Given this list of marker genes PEX12, POMT1 (protein O-mannosyltransferase 1), PEX13, TRAF7, GLE1, CHRND, VCP, DLL4, KIF1B, TPM2, SNX10, ALG2, PEX3, HLA-DRB1, PEX14, SELENON, DNAJB6, PEX5, SUFU, SMARCB1, MYMX, SGCD, PI4KA, LRP12, DMPK, MYMK, ANTXR1, SLC39A14, TCIRG1, COL6A1, SOST, POMT2, MYPN, HK1, BIN1, LAMB2, CHKB, BAP1, ADNP, LRP4, SQSTM1, SLC25A4, SLC25A1, KLHL40, XRCC2, PEX1, PEX11B, MUSK (muscle associated receptor tyrosine kinase), FRG1, YME1L1, SYNE1, CHCHD10, SMO, CHD7, SUCLA2, MPZ, CNTNAP1, PEX10, DPAGT1, SRPX2, PIK3CA, SH3TC2, CHRNB1, SCN4A, ADCY6, MYO9A, ALG14, ITPR1, UBA2, NEB, ANKH, MYL2, FKRP, CRPPA, PTRH2, PEX6, TOR1A (torsin family 1 member A), NEFL, LARGE1, GSN, GJC2, BAG3, SIX5, TERT, SALL4, OSTM1, AKT1, MTM1, MTMR14, SEMA3E, TTN, ADA2, TWNK, TFAP2A, SIX1, TRIM32, REV3L, PEX2, ADGRG1, PABPN1, RAPSN, POLG, BMS1, FKTN, COL13A1, PEX19, SPEG, ASAH1, MEGF10, KBTBD13, SLC52A2, SLC12A6, UBE2T, TUBB3, SNAP25 (synaptosome associated protein 25), RRM2B, CLCN7, TGFB1, BICRA, TUBB6, CRYAB (crystallin alpha B), MYH7, UBA1, TK2, GAN, PDGFB, LAMA2, CHRNE, SCO2, TFG, CRLF1, STAG2, DNM2, POLG2 (DNA polymerase gamma 2, accessory subunit), PEX26, GJA1, SLC19A3, SLC5A7, GMPPB, VAMP1, MTMR2, LMOD3, ITGB4, COL6A2, MTRFR, PUF60, GFPT1, CAPN3, COLQ, RYR1, PEX16, SMARCE1, MGME1, CHRNA1, ZC4H2, SLC18A3, CFL2, LRP5, HOXB1, ACTA1, NF2, TPM3, SPTBN4, PTDSS1, SUPT16H, ABCA1, CHAT, SYT2 (synaptotagmin 2), SLC52A3, AGRN, TRPV4, EBF3, PLEC, DES, GNE, AMER1, KLHL41, BTNL2, KMT2D, COL12A1, KY, DOK7, AK9, EYA1, SHMT2, NOD2, SMCHD1, ANO5, PLXND1, here is a description of the gene set: Human Gene Set: HP_ABNORMAL_SEVENTH_CRANIAL_PHYSIOLOGY Abnormal seventh cranial physiology Abnormality of the seventh cranial nerve sometimes also referred to as the facial nerve. species: Homo sapiens